Given this list of marker genes Gm5766, Khsrp, Rpl6, Rpl18a, Eef1b2, Eif3h, Cyp17a1, Rps8, Dnm1, Nsa2, Rpl29, Lalba, Eef1a1, Rpl10, Rps3, Rpl21, Rps6, Ptms, Arid5b, Cpt1b, Fthl17e (ferritin, heavy polypeptide-like 17, member E), Rps4x, Myl3, Rack1 (NCBI Gene Id 14694), 1110006O24Rik, Eif3f, Rpl4, Rps19, Eef1g, Raver2, Rpl14, 1700006J14Rik, Rps7, Syt10, Tcf7l2, Kif21b, Rps5, here is a description of the gene set: The tuberous sclerosis complex (TSC) proteins TSC1 and TSC2 regulate protein translation by inhibiting the serine/threonine kinase mTORC1 (for mammalian target of rapamycin complex 1). However, how TSC1 and TSC2 control overall protein synthesis and the translation of specific mRNAs in response to different mitogenic and nutritional stimuli is largely unknown. We show here that serum withdrawal inhibits mTORC1 signaling, causes disassembly of translation initiation complexes, and causes mRNA redistribution from polysomes to subpolysomes in wild-type mouse embryo fibroblasts (MEFs). In contrast, these responses are defective in Tsc1(-/-) or Tsc2(-/-) MEFs. Microarray analysis of polysome- and subpolysome-associated mRNAs uncovered specific mRNAs that are translationally regulated by serum, 90% of which are TSC1 and TSC2 dependent. Surprisingly, the mTORC1 inhibitor, rapamycin, abolished mTORC1 activity but only affected approximately 40% of the serum-regulated mRNAs. Serum-dependent signaling through mTORC1 and polysome redistribution of global and individual mRNAs were restored upon re-expression of TSC1 and TSC2. Serum-responsive mRNAs that are sensitive to inhibition by rapamycin are highly enriched for terminal oligopyrimidine and for very short 5' and 3' untranslated regions. These data demonstrate that the TSC1/TSC2 complex regulates protein translation through mainly mTORC1-dependent mechanisms and implicates a discrete profile of deregulated mRNA translation in tuberous sclerosis pathology. Mouse Gene Set: BILANGES_SERUM_RESPONSE_TRANSLATION species: Mus musculus Genes translationally repressed upon serum deprivation in MEF cells (embryonic fibroblast). from publication Bilanges B, Argonza-Barrett R, Kolesnichenko M, Skinner C, Nair M, Chen M, Stokoe D (PMID 17562867)